The following is a description of a gene set: species: Mus musculus part of: Metabolism of nucleotides This event has been computationally inferred from an event that has been demonstrated in another species.<p>The inference is based on the homology mapping from PANTHER. Briefly, reactions for which all involved PhysicalEntities (in input, output and catalyst) have a mapped orthologue/paralogue (for complexes at least 75% of components must have a mapping) are inferred to the other species. Reactome Pathway: Nucleotide salvage electronically inferred by orthology from the curated human pathway, and this is the list of marker genes: Cda, Adal, Uckl1, Uck1, Gmpr, Pnp, Ada, Tymp, Ampd3, Tk1, Dguok, Dck, Pudp, Pnp2, Upp1